The following is a description of a gene set: Reactions triggered in response to the presence of a Gram-negative bacterium that act to protect the cell or organism. Human Gene Set: GOBP_DEFENSE_RESPONSE_TO_GRAM_NEGATIVE_BACTERIUM species: Homo sapiens, and this is the list of marker genes: DEFB121, LCE3C, GSDMD, TNFRSF14, DEFB136, ELANE, IL6, TUSC2, IL23R, DEFB123, RPL30, CST11, DEFB128, IL17F, DEFB103B, LCE3B, F2RL1, BPI, DEFB119, DEFB106B (NCBI Gene Id 503841), AQP1, IRGM, DEFB104A, OPTN, TSLP, DEFB115, PRKD1 (protein kinase D1), IL22RA1, DEFB106A, RNASE6, RPS19, DEFB107B, DEFA5, NOS2, CD4, VIP, IL17A, DEFB104B, IL12B, CXCL6, SELP, RARRES2, CALCA, PYCARD, CAMP (cathelicidin antimicrobial peptide), GALP, F2, CHGA, DCD, MR1, TREM1, ADGRB1, DEFB132, IGHM, ROMO1, LALBA, DEFA1 (NCBI Gene Id 504182), FCN2, CD160, LTF, ADM, DEFB107A, CTSG, RNASE7, DEFA1B, DAO, PRB3, H2BC12, HAMP, NOD1, DEFA3, DEFA6, B2M, DEFB118, DEFB127, DEFB4A, DEFB135, DEFB1, TREM2, APP, DEFB114, IL6R, DEFA4, LBP, NFKBIZ, DEFB126, DEFB103A, TAC1, TFEB, SERPINE1, IL23A, SLC11A1 (solute carrier family 11 member 1), DEFB125, UMOD, TLR4, DMBT1, NPY, RNASE3, HMGB2, GSDMB, TLR9, LYPD8, H2BC11, LCE3A, LYZ, SSC5D, MPEG1, RNASE2, AZU1, MMP7, RNASE8, DROSHA